The following is a description of a gene set: species: Homo sapiens Diaphyseal dysplasia Human Gene Set: HP_DIAPHYSEAL_DYSPLASIA, and this is the list of marker genes: TMEM165, SPRED1, TBXAS1 (thromboxane A synthase 1), TMEM53, NF1